The following is a description of a gene set: Human Gene Set: SMIRNOV_RESPONSE_TO_IR_6HR_DN Genes down-regulated in B lymphocytes at 6 h after exprosure to 10 Gy dose of ionizing radiation. Radiation exposure through environmental, medical, and occupational settings is increasingly common. While radiation has harmful effects, it has utility in many applications such as radiotherapy for cancer. To increase the efficacy of radiation treatment and minimize its risks, a better understanding of the individual differences in radiosensitivity and the molecular basis of radiation response is needed. Here, we integrated human genetic and functional genomic approaches to study the response of human cells to radiation. We measured radiation-induced changes in gene expression and cell death in B cells from normal individuals. We found extensive individual variation in gene expression and cellular responses. To understand the genetic basis of this variation, we mapped the DNA sequence variants that influence expression response to radiation. We also identified radiation-responsive genes that regulate cell death; silencing of these genes by small interfering RNA led to an increase in radiation-induced cell death in human B cells, colorectal and prostate cancer cells. Together these results uncovered DNA variants that contribute to radiosensitivity and identified genes that can be targeted to increase the sensitivity of tumors to radiation. from publication Smirnov DA, Brady L, Halasa K, Morley M, Solomon S, Cheung VG (PMID 21844125) studied in species Homo sapiens, and this is the list of marker genes: ATP8A1, ZNF318, CDK5R1, CENPF, PTPRC, IL16, EGR3, EVI2A, MACIR, CACNA1A, SCD, RNASE6, POLR3G, SLC19A1, TNF, PTPRCAP, SUN2 (Sad1 and UNC84 domain containing 2), RGCC, GGA2, PSRC1, BUB1, ZBTB32, GPR18, ENTPD1, IER2, AIM2, LPCAT4, CR2, KIF23 (NCBI Gene Id 981, kinesin family member 23), SLC16A3, HEY1, RNASET2, CCNG2, CLEC2D, EGLN3, UBE2C, P4HA1, DLGAP5, CCR6 (NCBI Gene Id 1235), CD55, RGS2, TMEM45A, PLK1, UBE2S, HK2, EGR1, CD69, FKBP4, PVRIG, ACAP1 (NCBI Gene Id 9744), GEMIN4, TRAF5, TLE3, TRAF3IP3, SMCO4, BNIP3, ASPM, LCP2, ATP2A3, CCL4, LTA (lymphotoxin alpha), MNT, DUSP2, CCNB1, TCL1A, INSIG2, NEK2, INSIG1, H1-10, CENPE, RGS1, NR4A2, RAB33A, ZNF395, ZFP36, HHEX, DEPDC1, P2RX5 (NCBI Gene Id 5026), EGLN1, SIPA1, KDM3A, MYC (MYC proto-oncogene, bHLH transcription factor), RIPOR2, CD22, ELOVL6, PDK1, ITGA4, AURKA, HILPDA, ACKR3, LDLR, H1-0 (NCBI Gene Id 3005), VGLL4, SLC2A3, KIF20A, KLF6, CCR1, KCTD12, KLF2, HMMR, MAFF, ARHGAP11A, TPX2, CYBB, CENPA, KIF14, GFOD1, CD300A, STS, OAS1, TRIB1, CDC20, SIT1, CDCA3